Given this list of marker genes Slc28a1, Slc29a3, Aqp9, Slc29a2, Slc28a2, Slc28a3, Slc43a3, Slc28a2b, Slc23a3, Slc29a1, here is a description of the gene set: The directed movement of a nucleobase, any nitrogenous base that is a constituent of a nucleoside, nucleotide, or nucleic acid, into, out of or within a cell, or between cells, by means of some agent such as a transporter or pore. Mouse Gene Set: GOBP_NUCLEOBASE_TRANSPORT species: Mus musculus